Given this list of marker genes ATF2, DHFR, HDAC4, CYP2E1, ADH1A, HDAC2, AHCY, ACSS2, HDAC3, EHMT2, ALDH1A3, HDAC1, HDAC7, HDAC5, ELP3, HDAC9, ALDH2, MTHFR, MTR, HDAC8, ALDH1A1, SLC19A1, ADH1C, HDAC10, ALDH1A2, HDAC6, MAT1A, TYMS, HAT1, KAT2B, ADH1B, here is a description of the gene set: Human Gene Set: WP_ETHANOL_EFFECTS_ON_HISTONE_MODIFICATIONS Ethanol effects on histone modifications species: Homo sapiens